The following is a description of a gene set: Human Gene Set: HP_RHOMBENCEPHALOSYNAPSIS Rhombencephalosynapsis Rhombencephalosynapsis is a rare brain malformation defined by midline fusion of the cerebellar hemispheres with partial or complete loss of the intervening vermis. species: Homo sapiens, and this is the list of marker genes: FOXH1, NODAL, DISP1, SIX3, DLL1, EXOC2, ZIC2, GLI2, SHH, TGIF1, STIL, CDON (cell adhesion associated, oncogene regulated), GAS1, PTCH1, FGF8, CRIPTO